Given this list of marker genes Coch (NCBI Gene Id 12810), Dcn, Comp, Gp5, Dpp4, Nid1, Serpinh1, Smad7, Lrrc15, Antxr1, Ctsl, Aebp1, Mmp13, Tnxb, Ctss, Sparcl1, Podn, Itgb1, Ache, Hsd17b12, 2300002M23Rik, Thbs1, Abi3bp, Ddr1, Itga9, Ccbe1, Vwf, Adgrg6, Lum, Ppib, Adam9, Ddr2, Tgfbi, Itga1, Mmp12, Pcolce2, Pdgfb, Vtn, Col6a1, Lox, Tmem131, Pcolce, Col6a2, Smad4, Itga3, Dspp, Ctsk, Itga11, C1qtnf1, Cspg4, P3h4, Srgn, Spock1, Itga10, Ctsb, Pdgfa, Ush2a, Ecm2 (NCBI Gene Id 71546), Chadl, Pak1, Hspg2, Adgrg1, Rell2, Tll1, Thbs4, Spock2, Gp6, Gpc1, Crtap, Spock3, Mrc2, Col6a4, Smad3, Sparc, Map1a, Itga2, here is a description of the gene set: Mouse Gene Set: GOMF_COLLAGEN_BINDING Binding to collagen, a group of fibrous proteins of very high tensile strength that form the main component of connective tissue in animals. Collagen is highly enriched in glycine (some regions are 33% glycine) and proline, occurring predominantly as 3-hydroxyproline (about 20%). species: Mus musculus